The following is a description of a gene set: species: Homo sapiens from publication Patil MA, Chua MS, Pan KH, Lin R, Lih CJ, Cheung ST, Ho C, Li R, Fan ST, Cohen SN, Chen X, So S (PMID 15735714) Human Gene Set: PATIL_LIVER_CANCER Genes up-regulated in hepatocellular carcinoma (HCC) compared to normal liver samples. Hepatocellular carcinoma (HCC) is one of the major causes of cancer deaths worldwide. New diagnostic and therapeutic options are needed for more effective and early detection and treatment of this malignancy. We identified genes that are highly expressed in HCC using DNA microarrays, and further characterized them in order to uncover novel tumor markers, oncogenes, and therapeutic targets for HCC. Using Gene Ontology annotations, genes with functions related to cell proliferation and cell cycle, chromatin, repair, and transcription were found to be significantly enriched in this list of highly expressed genes. We also identified a set of genes that encode secreted (e.g. GPC3, LCN2, and DKK1) or membrane-bound proteins (e.g. GPC3, IGSF1, and PSK-1), which may be attractive candidates for the diagnosis of HCC. A significant enrichment of genes highly expressed in HCC was found on chromosomes 1q, 6p, 8q, and 20q, and we also identified chromosomal clusters of genes highly expressed in HCC. The microarray analyses were validated by RT-PCR and PCR. This approach of integrating other biological information with gene expression in the analysis helps select aberrantly expressed genes in HCC that may be further studied for their diagnostic or therapeutic utility., and this is the list of marker genes: UQCC6, STC1, F13A1, CABLES2, OGT, LSM4, RPRD2, VWF, NCOA2, DVL3, PIR, LINC03124, RTN3, PACC1, NUP133, ABCF1, DGCR2, LAGE3, SQLE, ARMC1, DDOST, ARID4B, DUS4L, DHFR, ENPP2, RDH10, TRIM28, SOS1, USP1, MAD2L1, KIF11, GMNN, CDK4, LMTK2, HSF2, GPSM2, EIF3E, H2BC4, IP6K1, TOP2A, PTBP3, ESPL1, MIS18A, RAD21, NUPR1, COL4A2, CDKN2AIPNL (NCBI Gene Id 91368), SSX4B, TRIP13, RRM2 (NCBI Gene Id 6241), NOTCH3, UCK2 (NCBI Gene Id 7371), PGAP4, KDM5B, ARHGAP39, HIPK2, MCM6, C2orf74-AS1, PRUNE1, TMCO1, DCAF7, RASSF3, LINC00294, SVIP, GMCL1, S100P, RHNO1, E2F3, RBM12B (NCBI Gene Id 389677), UBE2T, AKR1C3, VAT1, NHERF1, ACACA, UBE2M, PLK4, KDELR3, XPOT, KIF23 (kinesin family member 23), CCDC93, NDRG1, DPM2, IGF2BP1, SAC3D1, PIK3C3, ASF1B, CRTAP, RFC4, STK35, KLF13 (NCBI Gene Id 51621), LYZ, PIEZO2, PKMYT1, SLC6A13, ARL2, AP1S1, DDX11, PRIM2, DLEU2, BAIAP2L2, SHKBP1, NLRP2, EFNA1, SNRPA1, TRMT1L, BBLN, RHBDD3, UQCRB, CAP2, B4GALT3, TLCD5, ETV1, TBC1D13, MCRS1, SLC39A10, FAM83H, ONECUT2, BBX, RPS16, NAP1L1, BOLA1, SHARPIN, CKS1B, TRAIP, ENSG00000284691, CD109, PDGFRB, ADSL, PPOX, ANKIB1, IFT81, CUL7, TMEM259, CCDC14, UBXN2B, PRKCA, BLZF1, MCM3, DPH1, RNF43, MALSU1, GDAP1, SNX27, EPS8L3, SLC29A1, TMEM237, MAML1, GPAA1, SNRPE, PGP, NCOA3, ILF3, MAL2, MAVS, ZNF512B, POLR2K, SCN8A, SHISA4, USP21, CDK7, SUCO, PTGFRN, HELLS (helicase, lymphoid specific), CHML, SCYL1, UBN2, NME2, TUBB, RHOBTB3, ACTR6, CALR, SLC38A6, MTDH, MYCN, MEF2D, PAFAH1B3, LINC01138, POLD1, IL21R, RAMP1, AP3S1, BEX2, TMPO, TUBG1, RBM3, RNF216P1, LINC01089, CUTA (cutA divalent cation tolerance homolog), FEN1, CDKN2C, DVL2, CLPTM1, TUBA1A, GNA12, EHMT2, BMI1, SMC4, LMNB2, GSTA4, PBK, TIMP1, CCDC117, NUCKS1 (nuclear casein kinase and cyclin dependent kinase substrate 1), H4C3, BPTF, NEU1, ELOVL5 (ELOVL fatty acid elongase 5), PLP2, RCN2, LAMP2, BPNT2, PRPF6, JMJD4, CHEK1 (NCBI Gene Id 1111), TDP2, KNSTRN, RPS5, ONECUT1, CYRIB, RB1CC1, OSBP2, THOC5 (THO complex subunit 5), BUB1, GABRE, CLSTN1 (NCBI Gene Id 22883), VPS72, TUBA3D, DDX12P, TMEM98, DYNC1H1, ARNT, U2SURP, ITGA2, PTPN14, RNF157, ZNF252P, MAFG, AACS, WASHC5, DCK, GPNMB, RAP2A, UBE2C, PHF21A, MAP4K4, CPLX2, HAUS3, CENPF, H2BC12, MIR4435-2HG, ATAD2, BAIAP2L1, BCAT2, STMN1, REG1A, CCNA2 (NCBI Gene Id 890), XPO7, NELFE, SESTD1, GRINA, LAPTM4B, IGSF1, LGR5, MAPK8IP2, CKLF (NCBI Gene Id 51192), UXS1, PCNA, EIF4EBP2, TRIM24, FAM72B, IDI1, UBE3B, CEP85, PLEKHF2 (NCBI Gene Id 79666), BCAP31 (NCBI Gene Id 10134), SRXN1, ZNF704, RPS20, EZH2, XPO5, CDCA5, HLTF, PCLAF, UBA2, ATRN, FDPS, COL1A2, NPR1, ACBD3, ALDH18A1, PSMD10, GRN (NCBI Gene Id 2896), FAM241B, TADA1, CAPN1, LBR, SOX12, BLTP2, PTP4A3, YWHAZ, PRKDC, MYO5C (NCBI Gene Id 55930), EML2, TUBG2, NFYA, SEMA5A, PPP1CC, SELENON, AGAP1, TAF6, HRCT1, KNTC1, ERMP1, RPS19, NHP2, RRM1, PRRC2C, NREP, GLA, COLEC12, RBCK1, MTSS1, FOXM1, CENPQ, SCD, ISL2, BAK1, PODXL, RAB11FIP1, AFP, NEDD4L, MXD4, S100A10, ARF3, BTN2A2, TMEM106C, MAP1B, TBCE, LOXL2, LARP1, NEK2 (NIMA related kinase 2), GPS1, MZT1, HIF1AN, FADS1, SNRPB, OLA1, KLB, HORMAD1, CENPU, XPO1, PTGES2, CDK1, PXMP4, SMG7, CDC6, FLAD1, PTPRF, HGS, HNRNPA2B1, MYBL2, ABCB10, NHSL3, PARP2, CETN2, NRM, CYSTM1, PLK1, MCM5, MOSPD1, NF2, RER1, UCHL5, UBAP2L, COL5A2, TEKT4P2, PRDX1, SUPT16H, GTF3C3, CDCA8, NUP205, DUSP12, TNPO1, HACD3, PRCC, CD47, C1orf43, CEP55, MBNL3, TMEM65, C6orf136, CDIN1, NCKIPSD, HMGN2, PPP2R5A, DKK1 (dickkopf WNT signaling pathway inhibitor 1), TTYH3, CBX1, CSNK2B, TP53BP1, NUP155, PGK1, APH1A, AGRN, PEG10, LPGAT1, FANCG, COPS5, DENND11, CYC1, GON4L, SPARC, AURKA, CLPTM1L, RTCA (NCBI Gene Id 8634), H2BC5, CD24, NCAPG2, PRPSAP1, RRAGD, CHAF1A, PSPH, CDCA7, PYGB, ENSG00000245748, LIG3, CD46, ETV4, MAZ, MYPOP, GRAMD1A, CNIH4, STK24, PLCG1, HDAC11, ARFGEF1, CAPG, FASTK, H2AC6, MID1IP1, PUF60, TCEA1, GARRE1, YKT6, RGS5, VPS50, ATP6AP1, TUBA4A, MRPL42, EXTL3, FBXO45, HJURP, SLC36A1, CENPW, MBOAT7, TPR, SF3B4, FABP5, YY1AP1, CREB3L2, ABCC6, RPL30, TOB1, DLGAP5, MPZL1, ARID3A, LAMA4 (NCBI Gene Id 3910), SNHG7, CPQ, THY1, NUP37, CENPJ, RECQL4, TP53I3, GCLM, RNF213, FKBP11 (FKBP prolyl isomerase 11), PTK2, CD34, FAM136A, CDC25A, PRIM1, NCSTN, MSH5 (NCBI Gene Id 4439), H2AX, UBE2Q1, NUF2, STXBP6, RPSA, IRF2BP2 (interferon regulatory factor 2 binding protein 2), POFUT1, CPD, RNF187, AGO1, PFDN6, INTS7, OSTM1, RTN2, PEX2, TSEN54, TARBP1, LINC00205, INAVA, MGAT4A, SPP1, BTN2A1, CLK2, DTL, CDC45, LCN2, PRKAB2, RPTOR, GPC3 (glypican 3), IARS1, CEP97, PPT2 (NCBI Gene Id 9374), LRRC42, FADS2, DIDO1, PAK1, XPR1, HCFC1, ENAH, ATP6V1H, DSP, SERPINB3, TSPAN8, RUSC1, TCF4, MINDY1 (MINDY lysine 48 deubiquitinase 1), TPD52, CANX, ZWINT, HEATR6, URM1, ABL2, ASAP1, KIF20B, TSPAN5, TPX2, PIGC, FLVCR1, ADAM15, ZWILCH, PARP12, SPMIP5, DLG5, UBD, RHOC, FGFR4, CDC42SE1, IFT20, CLGN, SEZ6L2, HMGA1, ERI3, MCM4, TBC1D5, ACLY, COL7A1, MSTO1, ANGEL1, TRMT61A, RCC2 (regulator of chromosome condensation 2), PLXNC1, AKT1S1, TROAP, SPATS2, DEPDC1B, SHC1, H2BC21, TYSND1, SLC39A1, CASP2, TXNRD1, ILF2, ELMO1, VARS1, SLC26A6, CPSF2, CEP192, ANXA2, ESCO2, HTATIP2, ALDOA, XAGE1A, SLC26A2, ENTREP3, CCDC88A, ZNF706, ZKSCAN1, CDC25B, TSN, DAB1, SLC1A4, HHAT (hedgehog acyltransferase), SKP2, AGO2, HPS4, COL4A1, CCT4, ARL4A, KPNA2, E2F1, CPNE1, SYPL1, SCAMP3 (NCBI Gene Id 255017), ORC3, GNPAT, SMG5, PIK3R2, PPARG, RBFOX2, PPM1F, IRAK1, PLOD3 (NCBI Gene Id 8985), CENPM, TK1, RAD1, RAB11A, LSM14B, TCOF1, TRIO, DONSON, CTSA, ZCCHC17, RAB3GAP2, AP3M2, PYGO2, CCT5, BSG, ANKRD27, CDKN3, ZNF652, USP30, NDRG3, PEA15, NUSAP1, HMMR, KLHL23, MPHOSPH9, TMEM45B (transmembrane protein 45B), UBR5 (ubiquitin protein ligase E3 component n-recognin 5), PAX8, PTTG1, SH3PXD2B, ZIC2, TP53BP2, TBL1XR1, MAF1, INTS8, XRCC3, CAMK2G, H1-0, TYMS, E2F2, WNK1, CLN3, NUDT1, NPM1